Given this list of marker genes KIAA0040, NDUFB8 (NADH:ubiquinone oxidoreductase subunit B8), GMPR, ADH1B, CRYBG3, IL6R, N4BP2L1, CREBL2, FABP5, UBA7, PCBP2, FAM117A, here is a description of the gene set: studied in species Homo sapiens Most gene expression profiling studies of mesothelioma have been based on relatively small sample numbers, limiting their statistical power. We did Affymetrix U133A microarray analysis on 99 pleural mesotheliomas, in which multivariate analysis showed advanced-stage, sarcomatous histology and P16/CDKN2A homozygous deletion to be significant independent adverse prognostic factors. Comparison of the expression profiles of epithelioid versus sarcomatous mesotheliomas identified many genes significantly overexpressed among the former, including previously unrecognized ones, such as uroplakins and kallikrein 11, both confirmed by immunohistochemistry. Examination of the gene expression correlates of survival showed that more aggressive mesotheliomas expressed higher levels of Aurora kinases A and B and functionally related genes involved in mitosis and cell cycle control. Independent confirmation of the negative effect of Aurora kinase B was obtained by immunohistochemistry in a separate patient cohort. A role for Aurora kinases in the aggressive behavior of mesotheliomas is of potential clinical interest because of the recent development of small-molecule inhibitors. We then used our data to develop microarray-based predictors of 1 year survival; these achieved a maximal accuracy of 68% in cross-validation. However, this was inferior to prognostic prediction based on standard clinicopathologic variables and P16/CDNK2A status (accuracy, 73%), and adding the microarray model to the latter did not improve overall accuracy. Finally, we evaluated three recently published microarray-based outcome prediction models, but their accuracies ranged from 63% to 67%, consistently lower than reported. Gene expression profiling of mesotheliomas is an important discovery tool, but its power in clinical prognostication has been overestimated. Human Gene Set: LOPEZ_MESOTHELIOMA_SURVIVAL_UP from publication López-Ríos F, Chuai S, Flores R, Shimizu S, Ohno T, Wakahara K, Illei PB, Hussain S, Krug L, Zakowski MF, Rusch V, Olshen AB, Ladanyi M (PMID 16540645) Top genes associated with favorable survival after surgery of patients with epithelioid mesothelioma.